The following is a description of a gene set: Mouse Gene Set: REACTOME_CITRIC_ACID_CYCLE_TCA_CYCLE Citric acid cycle (TCA cycle) studied in species Mus musculus, and this is the list of marker genes: Mdh2, Ogdh, Sdhaf4, Nnt, Dlst, Nfs1, Aco2, Mrps36 (NCBI Gene Id 66128), Idh3a, Lyrm4, Cs, Iscu, Trap1, Suclg1, Sdha, Sdhaf3, Idh2, Sucla2, Sdhc, Sdhaf1, Sdhaf2, Dld, Suclg2, Isca1, Sirt3, Idh3g, Sdhd, Isca2, Sdhb, Fh1, Idh3b, Fxn (frataxin), Acat1